Given this list of marker genes MICAL1, GAL, SCN8A, RELN, NPRL3, PRRT2, NPRL2, LGI1, DEPDC5, PDE2A, here is a description of the gene set: Human Gene Set: HP_PSYCHIC_EPILEPTIC_AURA species: Homo sapiens Aura with affective, mnemonic or composite perceptual phenomena including illusory or composite hallucinatory events. Psychic epileptic aura